Given this list of marker genes Trem2, Tapbpl (TAP binding protein-like), Fgl2, Cd74, Ythdf1, Was, Pycard, Ccl21a (C-C motif chemokine ligand 21 (serine)), Thbs1, Ccr7, Nod1, Cd68 (NCBI Gene Id 12514), H2-Oa, Hfe, Tap2, Ccl19, Nod2, Ptpn22, H2-Ob, Fam3d, Slc11a1, Clec4b2, here is a description of the gene set: studied in species Mus musculus Any process that modulates the frequency, rate, or extent of antigen processing and presentation. Mouse Gene Set: GOBP_REGULATION_OF_ANTIGEN_PROCESSING_AND_PRESENTATION